The following is a description of a gene set: studied in species Homo sapiens Human Gene Set: GSE3982_MAST_CELL_VS_TH2_DN from publication Jeffrey KL, Brummer T, Rolph MS, Liu SM, Callejas NA, Grumont RJ, Gillieron C, Mackay F, Grey S, Camps M, Rommel C, Gerondakis SD, Mackay CR (PMID 16474395) In the present study we used Affymetrix oligonucleotide microarrays to produce gene transcription profiles for the major leukocyte types in humans. This comprehensive dataset enabled us to not only establish which genes were expressed in each leukocyte type, but also which genes were expressed in each subset after activation. The used of a comprehensive dataset of gene profiles from all the major human leukocyte subsets enabled a novel and powerful means for identification of genes associated with single leukocyte subsets, or different immune paradigms. Genes down-regulated in comparison of mast cells versus Th2 cells., and this is the list of marker genes: PTMS, IGHM (NCBI Gene Id 3507), NUP85, LMNB1, GSTA4, ADRM1, MAPKAPK3, ENSG00000291006, TMEM134, ESF1, DDX51, PRDX3, ARMCX2, MUTYH, KIF20B, XAB2, SFXN1, EXOSC9 (exosome component 9), ATAD2, POLR2C, GMNN, ZNF281, CCL1, ZDHHC14, SPAG5, SLC25A10, PXMP4, CEP152, PPP1R2, NEU3, CACNA1C, FUT8, MAPK11, POLD1, SSRP1, LRCH3, DDX18, GNL1, GBP1, CTPS1, PA2G4, PIEZO1, PITPNM1, CKS1B, FOXM1, MRPS2, CLN6, H3C1, ALPL, ETAA1, BLM, CLEC2D, SLC5A6, C19orf53, PCDH11Y, P2RY11, TRIM25, CDC25A, URB1, ERF, SLC39A9, ZNF207, TCERG1, EPAS1, TRIP13, PPP1R7, SPOUT1, LAIR2, TIMELESS, METRN, MPZL1, GABRB3, PTPN7, ABCG2, CSNK2B, BORA, MYOF, CD27, TRAF1, NDC1, PAXIP1, PMCHL1, RRP7A, ITGAE (NCBI Gene Id 3682), CD7, AURKA, PLK1, LIG1, RAMP1 (NCBI Gene Id 10267), USP39, HP1BP3, SRSF11, SACS, KIR2DL4, SMC4 (structural maintenance of chromosomes 4), MIS18A, MSH2, THAP7, PGGHG, JPT1, ARFIP2, PPP6R2 (NCBI Gene Id 9701), NUP188, EBP, MORC4, ETHE1, CENPI, TDP1, CTC1, PIWIL2, CRYBG3, KIF1B, TMEM204, RPA1, RAN, POU2F1, RSRC1, NUP37, DENND1C, IL27RA, GOLGA8A, MCM3, GPT, RPL13P5, BACH2, SP140, TBC1D31 (NCBI Gene Id 93594), ARMC6, GVINP1, INPP4B, ALDH3A2, TIPIN, FKBP5, ADGRG1, KLRC3, CASP9, PNO1, NUDT21, GPN2, TPR, TMEM135 (transmembrane protein 135), APLP1, P2RY10, MRPL58, TMPRSS3, ELP4, MRPL42 (NCBI Gene Id 64974), APOBEC3B, GZMB, MAZ, ACACA, MYL6B, THRAP3, DUSP2, OMD, MYH10, FBXO21, ECHDC1, TPD52, BLMH, CNOT7, PPFIBP1, ZEB1, ZDHHC24, XPO4, COQ3, QRSL1, PIP5K1B, KRTAP4-7 (keratin associated protein 4-7), GMEB1, ETFB, SDC4, POLR2D, TMEM156, MRPS15, FRYL, INVS, ORC6, RIBC2, MPZL2, EIF3I, CDC45, MRPL11, SPINK2, MIF, TUSC2, PDK1, BIRC5, CENPS, CFLAR, NFAT5, FADD, DCTPP1, TBX21 (T-box transcription factor 21), QSER1, MAP4K2, TRAF3IP3, SGSH, TOMM40, DGKA